Given this list of marker genes Fkbp6, Gpat2, Ddx4, Piwil4, Tdrkh, Mael, Henmt1, Tdrd6, Fbxo24, Mov10l1, Tdrd12, Pld6, Pnldc1, Tdrd7, Piwil2, Exd1, Tdrd9, Gtsf1 (NCBI Gene Id 74174), Piwil1, Tex15, Tdrd1, here is a description of the gene set: A process leading to the generation of a functional piRNA. piRNAs (Piwi-associated RNAs) are a class of 24- to 30-nucleotide RNAs derived from repeat or complex DNA sequence elements and processed by a Dicer-independent mechanism. Mouse Gene Set: GOBP_PIRNA_PROCESSING studied in species Mus musculus